Given this list of marker genes OAZ1, PIK3CB, RNF113A, NAA50, TTBK2, AIDA, LRRC47, TRABD, SRSF1, MSMO1, TCEA2, EXT1, TMEM9B, PRSS8, PSMA5, DHX58, CASK, EOGT, GALNT7, EIF1AX, GLI1, DDX42, DDX4, WHRN, MPZL2, TIMP4, MED23, ZNF184, LSM14A, OMD, ROS1, IER2, ENTPD1, IGLV6-57, ZNF107, DGCR2, GSDME, TBL1X, DMXL1, CCL2, TUBA1C, FDFT1, SYPL1, CBLL1, CD46, BRD3, SEPTIN7, TNFRSF21, TUBGCP3, GARRE1, MAIP1, PECR, ASXL2, KAT2B, NDUFB3, RBM47, CCDC86, SRPX2, UBA3, FCGR2C, DBR1, ZNF217, NFE2, PRDM4, PLGRKT, OSBPL8, CELP, GCA, PRG3, BLVRA, ROGDI, SRP19, PAEP, FXYD6, LITAF, CEBPG, CASP4, CUL1, FRYL, ZMYND8, SLC19A1, MS4A3, CD47, ACBD3, ASAH1, SLC8A2, NKX3-2, BRS3, FRS3 (fibroblast growth factor receptor substrate 3), TASOR, H2BC10, ENTREP2, PPP1R12A, EMG1, MFSD1, MEGF9, ZNF134, HOXC13, RIC8A, RRH, RPL12, ARID3A, MRPS2, NUAK1, ZBTB20, POLR1HASP, UBA2, IFNA5, PHKG1, NR5A1, LINC00472, PDS5B, CD79B, MIS12, TMEM132A, CDH20, GRK5, AQP3, GPC3, MTNR1A, USP15, TTI1, COL6A1, NSD3, PPT1, CYB5R4, DEK, PMM1, HIVEP2, PCIF1, GTPBP6, MVB12B, SLC25A14, DPP8, MAP4K5, CCDC92 (coiled-coil domain containing 92), CDC42BPA, CDC23, PTPRF, KRT35, HMGCS2 (3-hydroxy-3-methylglutaryl-CoA synthase 2), CLEC2B, ALDH9A1, PBLD, SYT13, TIMM17A, NOTCH1, MTM1, PENK, FOXK2, FOXI1, KLF13, PPARA, IKZF3, BPGM, PEX2, CRYBB2P1, HLA-B, SAP30L, SOS2, ELAVL1, SNCG, RPIA, TUFM, INHBB, TBCC, CILK1, MRPS22, NAAA, AVL9, CARD8 (NCBI Gene Id 22900), NUP62CL, SLC35F6, TAF11, TLK1, BTC, METTL13, CERS2, DNAJB1, FAM120A, HSPG2, DIRAS2, GRAPL-AS1, CRISP2, PPP3CA, EFCAB14 (EF-hand calcium binding domain 14), SLC2A2, DNASE1L1, KCNA6, RNF5, ABI1, CCDC88C, ZNF106 (NCBI Gene Id 64397), FRAT1, CNOT1, LILRA2, HTR1E, SNTA1, DERA, here is a description of the gene set: species: Homo sapiens Human Gene Set: GSE3982_CTRL_VS_LPS_1H_NEUTROPHIL_UP from publication Jeffrey KL, Brummer T, Rolph MS, Liu SM, Callejas NA, Grumont RJ, Gillieron C, Mackay F, Grey S, Camps M, Rommel C, Gerondakis SD, Mackay CR (PMID 16474395) In the present study we used Affymetrix oligonucleotide microarrays to produce gene transcription profiles for the major leukocyte types in humans. This comprehensive dataset enabled us to not only establish which genes were expressed in each leukocyte type, but also which genes were expressed in each subset after activation. The used of a comprehensive dataset of gene profiles from all the major human leukocyte subsets enabled a novel and powerful means for identification of genes associated with single leukocyte subsets, or different immune paradigms. Genes up-regulated in comparison of untreated neutrophils versus neutrophils treated with LPS (TLR4 agonist) at 1 h.